The following is a description of a gene set: species: Mus musculus from publication Chen Y, Wang X (PMID 31504780) Mouse Gene Set: MIR_6929_3P Genes predicted to be targets of miRBase v22 microRNA mmu_miR_6929_3p in miRDB v6.0 with MirTarget v4 prediction scores > 80 (high confidence targets)., and this is the list of marker genes: Ankrd66, Phex, Rfxank, Tmtc2, Iqck, Zbtb4, Brwd3, Ptf1a, Gml, Degs1, Musk, Snca, Phaf1, Spata1, Sorbs2, Nexmif, Kcnip1, Zfp367, Cdh22, Btg3, Smad2, Eri1, Tmx4, Kif20a, Etv6, Igdcc3, Zfp14, Slitrk5 (NCBI Gene Id 75409), Nedd9, Abl2, Kcmf1, Rasgrp4, Tmem170b, Pabpc4, Cmtr2, Klhl15, Gria2, Pir, Nlrp4b, Dgkh, Racgap1, Tent5a, Epb41l1, Esr1, Map3k1, Ehf, Rgs19, Nfat5, Ccdc62 (coiled-coil domain containing 62), Tmem100